The following is a description of a gene set: species: Homo sapiens Frontal lobe dementia Human Gene Set: HP_FRONTAL_LOBE_DEMENTIA, and this is the list of marker genes: TREM2, PRKN, LRRK2, CHCHD10, CSF1R, TBP, PODXL, FTL, PSEN1, SNCA, UCHL1, MAPT, PINK1 (PTEN induced kinase 1), TYROBP, HTRA2, PARK7, VPS13C, SYNJ1, DNAJC6